The following is a description of a gene set: Human Gene Set: GOBP_REGULATION_OF_SYSTEMIC_ARTERIAL_BLOOD_PRESSURE_BY_CIRCULATORY_RENIN_ANGIOTENSIN The process in which angiotensinogen metabolites in the bloodstream modulate the force with which blood passes through the circulatory system. The process begins when renin is released and cleaves angiotensinogen. studied in species Homo sapiens, and this is the list of marker genes: ATP6AP2, REN, ACE2 (angiotensin converting enzyme 2), ACE (NCBI Gene Id 654142), OR51E2, AGTR2 (angiotensin II receptor type 2), EDNRB, CPA3, F2R, F2RL1, GJA5, ENPEP, PCSK5, CMA1, COMT, ANPEP, PRCP, PREP, CTSZ, CTSG, NDST2, SUCNR1, MME